Given this list of marker genes USP24, MMP12, SERPING1, USP25, USP33, MMP13, USP53, CTSG (cathepsin G), SERPINE2, SERPIND1, CTSK, TIMP3, USP16, USP14, ADAM10, MMP9, USP1, USP32, ADAM9 (ADAM metallopeptidase domain 9), USP15, here is a description of the gene set: from publication Wilson TJ, Nannuru KC, Futakuchi M, Sadanandam A, Singh RK (PMID 18632634) studied in species Homo sapiens Protease genes up-regulated at tumor-bone interface compared to the tumor alone area. Human Gene Set: WILSON_PROTEASES_AT_TUMOR_BONE_INTERFACE_UP Breast cancer commonly causes osteolytic metastases in bone, a process that is dependent on tumor-stromal interaction. Proteases play an important role in modulating tumor-stromal interactions in a manner that favors tumor establishment and progression. Whereas several studies have examined the role of proteases in modulating the bone microenvironment, little is currently known about their role in tumor-bone interaction during osteolytic metastasis. In cancer-induced osteolytic lesions, cleavage of receptor activator of nuclear factor-kappaB ligand (RANKL) to a soluble version (sRANKL) is critical for widespread osteoclast activation. Using a mouse model that mimics osteolytic changes associated with breast cancer-induced bone metastases, we identified cathepsin G, cathepsin K, matrix metalloproteinase (MMP)-9, and MMP13 to be proteases that are up-regulated at the tumor-bone interface using comparative cDNA microarray analysis and quantitative reverse transcription-PCR. Moreover, we showed that cathepsin G is capable of shedding the extracellular domain of RANKL, generating active sRANKL that is capable of inducing differentiation and activation of osteoclast precursors. The major source of cathepsin G at the tumor-bone interface seems to be osteoclasts that up-regulate production of cathepsin G via interaction with tumor cells. Furthermore, we showed that in vitro osteoclastogenesis is reduced by inhibition of cathepsin G in a coculture model and that in vivo inhibition of cathepsin G reduces mammary tumor-induced osteolysis. Together, our data indicate that cathepsin G activity at the tumor-bone interface plays an important role in mammary tumor-induced osteolysis and suggest that cathepsin G is a potentially novel therapeutic target in the treatment of breast cancer bone metastasis.